The following is a description of a gene set: part of: TNFR2 non-canonical NF-kB pathway studied in species Mus musculus Reactome Pathway: TNF receptor superfamily (TNFSF) members mediating non-canonical NF-kB pathway electronically inferred by orthology from the curated human pathway This event has been computationally inferred from an event that has been demonstrated in another species.<p>The inference is based on the homology mapping from PANTHER. Briefly, reactions for which all involved PhysicalEntities (in input, output and catalyst) have a mapped orthologue/paralogue (for complexes at least 75% of components must have a mapping) are inferred to the other species., and this is the list of marker genes: Tnfsf11, Birc3, Tnfrsf11a, Tnfsf12, Cd40lg, Lta, Tnfrsf13c, Traf3, Tnfsf14, Map3k14, Ltb